Given this list of marker genes Card10, Klf4, Meox2, Itgb1bp1, Rhoa, Dll4, Spred1, Map2k5, Mmrn1, Thbs1, Hdac5, Notch1, Pik3r2 (NCBI Gene Id 18709), Tbxa2r, Pdcd10, Mmrn2, Stard13, here is a description of the gene set: Mouse Gene Set: GOBP_NEGATIVE_REGULATION_OF_CELL_MIGRATION_INVOLVED_IN_SPROUTING_ANGIOGENESIS Any process that decreases the frequency, rate or extent of cell migration involved in sprouting angiogenesis. Cell migration involved in sprouting angiogenesis is the orderly movement of endothelial cells into the extracellular matrix in order to form new blood vessels contributing to the process of sprouting angiogenesis. studied in species Mus musculus